The following is a description of a gene set: Any process that activates or increases the frequency, rate or extent of adipocyte differentiation. Mouse Gene Set: GOBP_POSITIVE_REGULATION_OF_FAT_CELL_DIFFERENTIATION species: Mus musculus, and this is the list of marker genes: Mapk14, Zbtb7b, Cds1, Cebpa (NCBI Gene Id 12606), Pim1, Sirt6, Rreb1, Zfp36, Lmo3, Ffar4, Dkkl1, Tmem64, Sfrp1, Stk4, Pparg, Bmp2, Medag, Zbtb16, Xbp1, Syap1, Gdf3, Rarres2, Trpm4, Creb1, Wdfy2, Aamdc, Carm1, Fndc5, Zfp385a, Klf5, Wnt5b, Axin2, Zc3h12a, Crebl2, Cmklr1, Sh3pxd2b, Zfp36l1, Vstm2a, Akt1, Noct, Sult1e1, Hnrnpu, Htr2c, Zbtb7c, Prdm16, Metrnl, Dact1, Ptgs2, Stk3, Sox13, Lpl, Lrp5, Bmp7, Asxl2, Napepld, Six1, Igf1, Cebpb, Htr2a, Adig, Ccdc3, Tfe3, Sav1, Fndc3b, Wif1, Mecom, Uchl3, Frzb, Tph1, Snai2, Id2, Sfrp2